The following is a description of a gene set: Human Gene Set: HP_TESTICULAR_ADRENAL_REST_TUMOR Testicular adrenal rest tumor (TART) is a abenign tumor of the testis. TART generally occurs multiply and bilaterally within the rete testis. Histologically, TART resemble adrenocortical tissue, which led to the name. The tumous are not encapsulated and consist of sheets or confluent cords of large polygonal cells with abundant eosinophilic cytoplasm. Testicular adrenal rest tumor species: Homo sapiens, and this is the list of marker genes: TXNRD2, NNT, MRAP, PRKAR1A, STAR, MC2R, CYP11B1, PDE11A